Given this list of marker genes TGFB1, ACP5, CUEDC2, TGFB2, TGFB3, EPX, IRAK3, NLRX1, ATG9A (NCBI Gene Id 79065), TWIST1, PRG2, AXL, here is a description of the gene set: studied in species Homo sapiens Any process that decreases the rate, frequency or extent of macrophage cytokine production. Macrophage cytokine production is the appearance of a chemokine due to biosynthesis or secretion following a cellular stimulus, resulting in an increase in its intracellular or extracellular levels. Human Gene Set: GOBP_NEGATIVE_REGULATION_OF_MACROPHAGE_CYTOKINE_PRODUCTION